The following is a description of a gene set: species: Homo sapiens part of: Intrinsic Pathway for Apoptosis Reactome Pathway: Activation and oligomerization of BAK protein tBID binds to its mitochondrial partner BAK to release cytochrome c. Activated tBID results in an allosteric activation of BAK. This may induce its intramembranous oligomerization into a pore for cytochrome c efflux., and this is the list of marker genes: BAK1, BID